Given this list of marker genes ICOS, CCNB1, PRKAR1A, BIRC6, KLC1, SHC1, VCL, RANBP2, MAPK9, EML4, CUL1, HDAC1, TNRC6C, PTPN6, RPS27A, MAPK1, STAT5A, SKP1, KIF5B, RRBP1, CARS1, TP53 (NCBI Gene Id 7157), TPM4, HIP1, CDKN1A, MIR21, RB1, LMO7, ZAP70, CLTC, FRS3, MAPK8, AGO2, JUN, PIK3CB, JUNB, MDM2, FRS2, AGO3, MECP2, TWIST1, CEBPB, TYK2, SQSTM1, STAT3, IL10RA, PPFIBP1, STRN, AGO4, BCL11A, NPM1, PIK3CA, SEC31A, PIK3R1 (phosphoinositide-3-kinase regulatory subunit 1), RBX1, GZMB, PIK3R2, MYH9, DCTN1, ZC3HC1, UBA52, IRF4, TPM3, FN1, MOV10, STAT1, TPR, WDCP, AGO1, GRB2, FOXM1, MCL1, IL22, UBB, ALK, GCC2, BCL2A1, UBC, RPS6, RNF213, DNMT1, PRF1, MAPK3, IRS1, PPM1B, PLCG1 (phospholipase C gamma 1), NOTCH1, EEF1G, MSN, TFG, IL10, EIF2AK3, ATIC, here is a description of the gene set: Reactome Pathway: Signaling by ALK in cancer species: Homo sapiens part of: Diseases of signal transduction by growth factor receptors and second messengers Anaplastic lymphoma kinase (ALK) was first identified in the context of an oncogenic fusion with nucleophosmin (NPM) in anaplastic large cell lymphoma (ALCL). NPM-ALK fusions occur in approximately 75-80% of ALCL cases and at lower frequencies in other cancers, including non-small cell lung cancer, neuroblastoma and inflammatory myofibroblastic tumors (IFTs). <br><br>In addition to NPM, fusions of ALK with nearly 30 other 5' partners have since been identified, although these tend to occur at lower frequencies in the cancers in which they appear. In general, ALK fusions combine the 5' end of the partner gene which contributes a dimerization domain with the intracellular portion of the ALK receptor including the kinase domain, and lead to constitutive signaling by virtue of the partner-domain mediated dimerization. <br><br>In addition to translocation events that lead to fusion proteins, the ALK gene also contributes to oncogenesis as a result of gene amplification and overexpression events, as well as being subject to activating missense mutations. <br><br>Oncogenic ALK activity can be targeted with tyrosine kinase inhibitors, although resistance often arises due to secondary mutations or activation of bypass pathways.